The following is a description of a gene set: Mouse Gene Set: KOHOUTEK_CCNT1_TARGETS Genes down-regulated in E14 ES (embryonic stem) cells upon knockdown of CYCT1 by RNAi. The positive transcription elongation factor b (P-TEFb) is essential for the elongation of transcription and cotranscriptional processing by RNA polymerase II. In mammals, it contains predominantly the C-type cyclin cyclin T1 (CycT1) or CycT2 and cyclin-dependent kinase 9 (Cdk9). To determine if these cyclins have redundant functions or affect distinct sets of genes, we genetically inactivated the CycT2 gene (Ccnt2) using the beta-galactosidase-neomycin gene (beta-geo) gene trap technology in the mouse. Visualizing beta-galactosidase during mouse embryogenesis revealed that CycT2 is expressed abundantly during embryogenesis and throughout the organism in the adult. This finding was reflected in the expression of CycT2 in all adult tissues and organs. However, despite numerous matings of heterozygous mice, we observed no CycT2(-/-) embryos, pups, or adult mice. This early lethality could have resulted from decreased expression of critical genes, which were revealed by short interfering RNAs against CycT2 in embryonic stem cells. Thus, CycT1 and CycT2 are not redundant, and these different P-TEFb complexes regulate subsets of distinct genes that are important for embryonic development. from publication Kohoutek J, Li Q, Blazek D, Luo Z, Jiang H, Peterlin BM (PMID 19364821) species: Mus musculus, and this is the list of marker genes: Abcb1b, Capns1, Chrnb1, Mylpf, Ccnt1, Eeig1, Bbs7, Cxcl16, Galm, S100a1, Col7a1, Pros1, Krt18, Bbs2, Magec2, Pgc, Tex19.1, S100a13, Dner, AA467197, Itgb4, Acadvl, Enpp5, Cldn4, Wdr45, Bmp1, Mroh1, Fhl2, Snhg11, Mvp, Pter, Slc39a4, Tbx3, Sfn, Cryab, Cd68, Pxdc1, Htra1, Aqp3, Abhd14b, Cln3, Anxa5, Arl4c, Gpx2, Stmn3, Tacstd2, Krt14, Hsd3b7, Sqstm1, Cltb, Ahnak2, Patl2